The following is a description of a gene set: Human Gene Set: GOBP_NEGATIVE_REGULATION_OF_MULTICELLULAR_ORGANISM_GROWTH studied in species Homo sapiens Any process that stops, prevents, or reduces the frequency, rate or extent of growth of an organism to reach its usual body size., and this is the list of marker genes: BBS2, STC2, ADRB1, GNAS, LGMN, PLAC8, GDF15, ADRB3, SOCS2, PTCH1, ADRB2, RAI1, FXN